The following is a description of a gene set: Iris transillumination defect Human Gene Set: HP_IRIS_TRANSILLUMINATION_DEFECT species: Homo sapiens Transmission of light through the iris as visualized upon slit lamp examination or infrared iris transillumination videography. The light passes through defects in the pigmentation of the iris., and this is the list of marker genes: HPS5, HPS6, DCT, BLOC1S3, LRMDA, COL18A1, OCA2, CHRDL1, BLOC1S5, WDR45, MC1R, ADAMTSL4 (ADAMTS like 4), CPAMD8 (C3 and PZP like alpha-2-macroglobulin domain containing 8), MITF, C1QTNF5